Given this list of marker genes Hmgxb4, Rbbp4, Smarca5, 0610010K14Rik, Smarca1, Bptf, Rbbp7, here is a description of the gene set: species: Mus musculus An ISWI complex that contains an ATPase subunit of the ISWI family (SNF2L in mammals), a NURF301 homolog (BPTF in humans), and additional subunits, though the composition of these additional subunits varies slightly with species. NURF is involved in regulation of transcription from TRNA polymerase II promoters. Mouse Gene Set: GOCC_NURF_COMPLEX